Given this list of marker genes SDHC, DLST, GNAQ, MDH2, SDHD, SDHA, VHL (von Hippel-Lindau tumor suppressor), SLC25A11, KIF1B, RET, FH, SDHAF2, TMEM127, NF1, SDHB, MAX, here is a description of the gene set: Arachnoid hemangiomatosis Human Gene Set: HP_ARACHNOID_HEMANGIOMATOSIS species: Homo sapiens The presence of multiple hemangiomas in the arachnoid.